Given this list of marker genes IL1B, TNFRSF10B, NFE2L2, MBTPS2, DDIT3, CASP2, BCL2L11, ERN1, PPP1R15A, EIF2AK3, RTCB, PMAIP1, TP53, EIF2S1, TXNIP, MBTPS1, CASP1, XBP1, HSPA5, ATF4, ATF6, BCL2, BBC3, BID, here is a description of the gene set: studied in species Homo sapiens Unfolded protein response Human Gene Set: WP_UNFOLDED_PROTEIN_RESPONSE